The following is a description of a gene set: studied in species Mus musculus Mouse Gene Set: GOCC_PARASPECKLES Discrete subnuclear bodies in the interchromatin nucleoplasmic space, often located adjacent to nuclear specks. 10-20 paraspeckles are typically found in human cell nuclei., and this is the list of marker genes: Nono, Bcl6, Alkbh5 (alkB homolog 5, RNA demethylase), Nudt21, Cpsf6, Hnrnpm, Pspc1, Bcl11a, Neat1, Sfpq